The following is a description of a gene set: studied in species Mus musculus Mouse Gene Set: chr10A1, and this is the list of marker genes: Rmnd1, Armt1, Gm46209, Gm4921, 4930598N05Rik, Gm22739, Gm23601 (NCBI Gene Id 115485753), Myct1, Fbxo5, Gm48758, Gm30570, Gm30674, Ginm1, Gm30906, Lats1, Gm15560, Gm9797, Gm5177, Ppil4, Gm3266, Gm48727, Ipcef1, Zc3h12d, Mthfd1l, Epm2a, Gm48750, Esr1, Akap12, Katna1 (NCBI Gene Id 23924), Stxbp5, Gm16149, Rgs17, Oprm1, Rab32, Gm19161, Gm25139, Gm8155, Gm21321, Gm31904, Gm20470, Gm28905, Tab2, Gm10097, Gm25635, Gm3213, Mtrf1l, Fbxo30, Lrp11, 4930553I21Rik, Ppp1r14c, Adgb, Zbtb2, Gm18703, 4930567K20Rik, Gm25410, Plekhg1, Gm25369, Vip, Gm23044, Gm24374, Gm6667, Gm46210, Ulbp3, Gm24726, Grm1, Ust, Gm25515, Rpl17-ps11, Nup43, Gm3318, Pcmt1, Gm16254, Mir5104, Gm25979, Cnksr3, Gm16074, Samd5, Gm22546, Iyd, 4930432B10Rik (NCBI Gene Id 74619), Ccdc170, Gm23680, Gm9930, H60c, Sash1, Gm25682, Gm15568, Shprh, Gm6150, Syne1, Ulbp1, Gm16148, B020014A21Rik, Gm47679 (predicted gene, 47679)